Given this list of marker genes TBC1D14, RNF152, FNDC3A, TFCP2L1, ARHGAP18, THRB (thyroid hormone receptor beta), ADGRF1, MYO10, PLCL1, HS6ST3, RERE, DPH6, ATP6V1A, FYB2, GMDS-DT, KIF21A, HIPK2, NRDC, XIST, SHOC1 (NCBI Gene Id 158401), CGNL1, PRKN, PACRG, ARL15, SLC26A7, TMEM213, BDP1, MACROD2, ATP6V1C2, DSP, OSBPL3, LIMCH1, RUFY3, PDE1C, CLIP1 (CAP-Gly domain containing linker protein 1), CA8, ITPR2, PICALM, RALGAPA1, TRIM2, BTBD9, ZSWIM6, NXPH2, SETBP1, RALGPS2 (Ral GEF with PH domain and SH3 binding motif 2), MAPK8, STK3, MTR, PPP3CA, FREM1, SLC4A1, NEDD4L, IGFBP5, CPEB4, LINC-PINT, PTGER3, SKAP1, FOXP1, CA12, EPS8, PRKG1, MBNL1, ATXN1, PRKCE, ITPR1, ITGA6, KANSL1L, ABCA5, PPP1R12B, PDE4D, PNISR, SEMA3C, SBF2, UBR3, FNBP1L, MSI2, GALNT17, NCOA2 (nuclear receptor coactivator 2), RAPGEF2, SAMD5, TMEM117, BRAF, LGR4, FBXL17, PLCG2, GRB14, ATP6V0A4, WWP1, PPARGC1A, PRKCA, NCOA1, LUC7L3, SNHG14, PSD3, COBLL1, NR3C2, KIAA1328, CACNB2, AHCYL2 (NCBI Gene Id 23382), LRMDA, EZR, FAF1, GLIS3, ESRRG, IL18, FER, PDE1A, THSD7A, TMEM101, MYO1D, DIP2C, SHROOM3, GULP1, ARHGEF28, MPPED2, NRXN3, AKAP9, KIAA1217, ITGAV, OXR1, GPAT3, PTPRJ, FOXO1, CAB39, TBC1D4, WWOX, CLNK, ATP6V0D2, ZBTB20 (zinc finger and BTB domain containing 20), SNTB1, FGD4, MAGI1, SCAPER, SCIN, TBC1D1, ABCC4, PCNX4, SLIT2, MAGI3, GPHN, GLCCI1, GNAQ, THRB-AS1, ADAMTSL1, RCAN2, RBM25, ADGRF5, DOCK8, MOB1B, MAP4K3, SUMF1, DLG1, here is a description of the gene set: Human Gene Set: LAKE_ADULT_KIDNEY_C20_COLLECTING_DUCT_INTERCALATED_CELLS_TYPE_A_CORTEX species: Homo sapiens from publication Lake BB, Chen S, Hoshi M, Plongthongkum N, Salamon D, Knoten A, Vijayan A, Venkatesh R, Kim EH, Gao D, Gaut J, Zhang K, Jain S (PMID 31249312)